Given this list of marker genes Ifitm3, Zfp36 (zinc finger protein 36), Trim14, Trim13, Trim32, Trim11, Ifitm7, Ubp1, Trim27, Trim62, Trim8, Trim31, Larp7, Sp100, Hexim1, Trim21, Mid2, Larp7-ps, here is a description of the gene set: Mouse Gene Set: GOBP_NEGATIVE_REGULATION_OF_VIRAL_TRANSCRIPTION Any process that stops, prevents, or reduces the frequency, rate or extent of viral transcription. species: Mus musculus